Given this list of marker genes C1QTNF5, RP2, GUCY2D, PCARE, RPE65, here is a description of the gene set: Human Gene Set: HP_FUNDUS_ATROPHY Fundus atrophy studied in species Homo sapiens